Given this list of marker genes Rock1, Tpm1, Panx1, Marcks, Fhod1, P2rx7, Anln (anillin, actin binding protein), Ptprc, here is a description of the gene set: species: Mus musculus Mouse Gene Set: GOCC_BLEB A cell extension caused by localized decoupling of the cytoskeleton from the plasma membrane and characterized by rapid formation, rounded shape, and scarcity of organelles within the protrusion. Blebs are formed during apoptosis and other cellular processes, including cell locomotion, cell division, and as a result of physical or chemical stresses.